Given this list of marker genes Ccdc112, Atrn, Slc18a2, Zfp612, Mtor, Zfp267, Gabrb3, Rab7, Enc1, Lrrfip1, Thnsl1, Rfx7, Ebf1, Pgm5, Zbtb49, Kdm3b (KDM3B lysine (K)-specific demethylase 3B), Rnf139, Nus1, Hpcal4, Sorcs1, Zfp113, Pappa, Marf1, Sash1, Gkn2, Gpr101, Rasd1, Jade1, E2f5, Ifi213, Pbrm1, Il1rap, Ace2 (angiotensin converting enzyme 2), Mlf1, Tenm2, Stat1 (NCBI Gene Id 98183), Gpr161, Ebag9, Senp6, Klhl29, Igfbp3, Ubash3b, Kansl1l, Acp3, Carf, Gabrg1, Pgm2l1, Ankmy2, Rbms3, Traf6, Zfp819, Mal, Shisa9, Nrxn1, Slc24a2, Clcc1, Dipk1a, Noa1, Zbtb2, AU041133, Lrfn5, Arl4a, Cyp26b1 (cytochrome P450, family 26, subfamily b, polypeptide 1), Per2, Zc3h12c, Wbp2 (WW domain binding protein 2), Cldn34b1, Sorbs1, Med19, Cast, Rfx1, Usp9x (NCBI Gene Id 77016), Ccdc160, Elavl4, Ifi44, Milr1, Pmepa1, Eif4a1, Snx27 (sorting nexin family member 27), Adamts12, Cert1, Notch2, 5730507C01Rik, Eif3a, Mbtd1, Tnfrsf11a, Ncam2, Sanbr, Atf2, Zfp69, Nsfl1c, Castor2, Rfx3, Dnajc19, Stk24, Trim2, Gdf2, Utrn, Trpv5, Rock1, Ctdsp1, Clptm1l, Scn1a, Fgf7, Ilrun, Wdr44, Insr (insulin receptor), Anks1b, Bbip1, Tet3, Dclk1, Pdzrn3, U2surp, Fam227a, Arih1, Clasp1, Mctp2, Nr3c2, Smpd3, Cebpz, Ccdc115, Cntnap2, Zfp598, Zswim6, Scamp1, Ssr1, Trpc1 (NCBI Gene Id 22063), Rnf11, Sh3yl1, Rbbp6, Ubqln2, Ror1, Adora1, Edem1, Mcu, Zfp781b, Zfp185, Kpna3, Zwilch, Ccdc181, Zfhx3, Nfasc, Slc1a2, Trpd52l3, Tceal7, Itih5, Rasgrp3, Agtr2, Thsd7a, Mab21l2, Brcc3, Lamp5, Ccdc167, Zfp827, Rbms2, Mb21d2, Fmr1, Nalf1, Gm4841, Hoxa5, Adamtsl1, Tnrc6b, Pou3f2, Eif4g3, Gpr22, Ikbkb, Grik2, Epc1, Zfp560, Ambn, Mapkbp1, Psen1, Plppr1, Rlig1, Abr, Igsf6, Fam20b, Tnfrsf10b, Gje1, Bnc2, Gria3, Rbm28, Psd2, N6amt1, Slf2, Gtf2ird1, D130043K22Rik, Rgs17, Lamp3, Ppip5k1, Slc10a7, Ppm1l, Rbm7, Abtb3, Csde1, Ebf2, Rps6ka6, Zfp971, Dcun1d4 (NCBI Gene Id 231295), here is a description of the gene set: from publication Chen Y, Wang X (PMID 31504780) Genes predicted to be targets of miRBase v22 microRNA mmu_miR_669n in miRDB v6.0 with MirTarget v4 prediction scores > 80 (high confidence targets). Mouse Gene Set: MIR_669N studied in species Mus musculus